The following is a description of a gene set: Genes predicted to be targets of miRBase v22 microRNA hsa-miR-1246 in miRDB v6.0 with MirTarget v4 prediction scores > 80 (high confidence targets). from publication Chen Y, Wang X (PMID 31504780) Human Gene Set: MIR1246 species: Homo sapiens, and this is the list of marker genes: ZNF425, ATP2B1, ANKDD1B, FAM53C, TBCK, EIF2AK3, ISCA1, DYNC1I1, ADAT2, LYPD1, CEP126, CDO1, LINC02694 (long intergenic non-protein coding RNA 2694), CNOT9, LENEP, SEPHS1, ADAM22, KLHL14, HLF, REPS2, TNFRSF8, SGO1, QTRT2, CREBL2, SCN3A, HTR5A, DLG1, DENND10, SCEL, RPL36A, GLRB, ELF5, DUSP18 (dual specificity phosphatase 18), RAB14, HECTD2, TAF9B, RTKN2 (NCBI Gene Id 254060), MIER1, COL6A6, GMFB (NCBI Gene Id 2764), MRPS14, C12orf71, ANTXR2 (NCBI Gene Id 118429), SLC38A2 (solute carrier family 38 member 2), DYRK1A, FPGT, NDFIP1, MYOT, SORBS2, SLC12A2, PANX1, KDM5A, OPRM1, ZCCHC14, PLEKHB2, ZNF888